Given this list of marker genes Myzap, Rprd2, Rpap2, Brf1, Polr2m, Rprd1b, Rprd1a, Recql5, Taf10, Gtf2h3 (general transcription factor IIH, polypeptide 3), Gtf2b, Gtf2a1, Brf2, Ercc3 (excision repair cross-complementing rodent repair deficiency, complementation group 3), here is a description of the gene set: Mouse Gene Set: GOCC_TRANSCRIPTION_PREINITIATION_COMPLEX species: Mus musculus A protein-DNA complex composed of proteins binding promoter DNA to form the transcriptional preinitiation complex (PIC), the formation of which is a prerequisite for transcription.